The following is a description of a gene set: Human Gene Set: HP_ABNORMAL_HEPATOBILIARY_SYSTEM_PHYSIOLOGY A functional anomaly of the hepatobiliary system studied in species Homo sapiens Abnormal hepatobiliary system physiology, and this is the list of marker genes: CBL, PEX12, SLC2A2, NPC1, CACNA1S, CTC1, SMPD1, TRMT10C (NCBI Gene Id 54931), SLC25A13, DLD, ASL, NPM1, TCF4, BAAT, TERC, NDUFS4, GALT, MPV17, RMND1, MRM2, ALG3, MT-ND5, PCK1, NRAS, PARN, GFM1, MRPS23, GSTZ1, SLC25A20, PGM1, GANAB, MT-ND2, MED12, AP1S1, TINF2, CLDN1, PEX1, LIPT1, AKR1D1, RINT1, LARS2, MT-ND4, ACVRL1, GDF2, CYP7B1, IFT122, ALMS1, RNU12, UNC13D, LYST, CYC1, MICOS13, MMEL1, TRMU, SRSF2, AP1B1, ACADM (NCBI Gene Id 51779), ENG (NCBI Gene Id 2022), ASAH1, USB1, JAG1, KRT18, PRF1, PORCN, SKIC3, RTEL1, AMACR, LIPA, DEF6, TALDO1, ALG8, IL12A, POT1, TMEM67, SLC30A10, ATP7B, PEX19, EIF2AK3, COA8, TMEM199, LARS1, DKC1, BRAF, GALM, SERPINA1, FH, SLC51A, COX16, ABCB4, CCDC47, TJP2, TNPO3, HMGCL, PEX10, ALDOB, BMP6, GATC, INPP5E, TET2, VPS50, STX11, ACAD9, ALG1, OCLN, PEX6, F5, TFAM, SC5D, RUNX1, TYMS, UGT1A1, ABCD3, HLA-DRB1, MAP2K1, MEFV (NCBI Gene Id 4210), DGUOK, ZNFX1, FECH, PARS2, MARS1, PNPT1, ATP8B1, F13A1, BCS1L, POU2AF1, SEMA4D, MRPS7, HADH, LRPPRC, DCDC2, NOP10, COQ2, ATRX, RYR1, MPI, ATP6AP2, HADHB, GCSH (NCBI Gene Id 2653), GPR35, STXBP2, UBR1, EPM2A, CPT1A, MT-TL1, FBP1, XIAP, IL18BP, MT-TV, HLA-B, SLC7A7, APOA1, PEX13, PTPN22, NHP2, ABCB11, ITCH, NAGS, RBM10, SCYL1, P4HA2, TERT, SCARB2, MT-TW, PEX2, OSTM1, SLC25A15, PEX16, IL12RB1, COG7, SMAD4, NR1H4, HADHA, MST1, HFE, HSD3B7, IFT172, CPT2, MT-ND3, UQCRC2, PEX14, SURF1, IL21R, GBE1, SH2D1A, DDOST, COG2, BLVRA, FADD, PIGA, STX5, POLG, MT-ND1, COG4, IARS1, H4C3, FAH, IRF5, ASXL1, MT-TN, F13B, PEX3, PEX26, NBAS, FARSB, TNFSF15, NHLRC1, MT-TK, SLC39A8, CC2D2A, PEX5, POLG2, CCDC115, ZFYVE19, PEX11B, OTC, QRSL1, MT-ND6, IKZF1, MT-ATP6, HBB, CALR, SPIB, VPS51, PKHD1, JAK2, RPGRIP1L, FOCAD, PCK2, ACTG2, SP110, BTNL2, WRAP53 (WD repeat containing antisense to TP53), MT-TT, GBA1